The following is a description of a gene set: A type of malformation of cortical development that primarily affects areas of neocortex. It can be identified on conventional magnetic resonance imaging as focal cortical thickening, abnormal gyration, and blurring between gray and white matter, often associated with clusters of heterotopic neurons. Human Gene Set: HP_FOCAL_CORTICAL_DYSPLASIA Focal cortical dysplasia species: Homo sapiens, and this is the list of marker genes: COPB2, MTOR, NPRL2, TSC2, DEPDC5, AKT3, DYNC1H1, COL4A1, NUP133, TSC1, PIK3CA, NPRL3, POMT1, CNTNAP2, SCO2